Given this list of marker genes ITK (NCBI Gene Id 3702), RASSF2, IFI30, SELPLG, BLM, BPNT2, SLC18A2, KIF2C, FN1 (fibronectin 1), CYTIP, CCDC88A, LTB, RET, TNC, CALU, BCAT1, TRIP13, HHIPL2, GNLY, SLC16A3, SERPINA6, BIRC5, MMP12, CDC20, CHST11, CD6, IGHV3-33, COL5A1, IL18R1, CEP55, TRAC (T cell receptor alpha constant), TCL1A, MMP11, EVI2A, LMO3, LCK, HLA-DRB1, GZMA, ISG20 (NCBI Gene Id 3669), CCN4, AIF1, APOBEC3B, OIP5, GINS2, CNTNAP2, HLA-DRB6, GPR183, MMP1, ITGB2, CD79B, IGKV1OR2-108, CD52, LILRB4, PSTPIP1, LRRC15, IGHV3-21, TDO2, HSD17B1, GLIPR1, CST7, MMP19, CREB3L1, MMP3, CPM, CCL11, GPR171, AHI1, IGLV3-19, GPSM2, CD40, TYMS, IGHV1-69, NEK2, IGKV1D-8, NARS2, RRM2, MMP9, SOAT1, APOC1, LST1, CD27, ADCY7, TRAF3IP3, CCR7, CD38, CDKN3 (cyclin dependent kinase inhibitor 3), TPK1, NPL (N-acetylneuraminate pyruvate lyase), GZMB, SELL, GPR65, THEMIS2, CD79A, LAMP3, TBC1D31, IGLV4-60, CALCRL, GINS1, FCGR3A, EGFL6, FCMR, DOCK2, PLAC8, LILRB2, TRBC1, TK1, SULF1, SQLE, FANCI, IGHV3-20, DTL, CXCL9, PLAUR, CLEC7A (NCBI Gene Id 64581), TPX2, STAG3, LOXL1, TRDC, COL11A1, DSC2, ARHGAP15, SLA, IGHG1, SLC7A5, CCNA2, CD1E, CXCL10, GZMK, CYLD, CD53 (CD53 molecule), S100P, GBP1, PTPRC, CD74, KMO, GRB2, CD2, LRP8, ADGRE2, CKS2, PRR16, CD3D, TRGC1, VCAN, CENPF, ITGAX, NET1, BCL2A1, MNDA, CCL4, DLGAP5, FCGR2A, LAPTM5, NID2, CHIT1, HYAL1, IL18, INHBA, GAB2, CH25H, MAP4K1, FKBP11, CDH11, SAMSN1 (SAM domain, SH3 domain and nuclear localization signals 1), CTSC, CCR1, SOX11, PRKCB, ITGA4, LGALS9, NUSAP1, TRBC2 (NCBI Gene Id 28638), HLA-DQA1, CCNB2, COTL1, LAT2, CD48, IGHV3-7, MAFB, CD19, CPNE7, IGKV1D-13, ECM1, ADAMDEC1, TOP2A, STAT4, MCM4, LCP2, SPC25, CD86 (CD86 molecule), CD69, IGHV3-47, BUB1B, TNFAIP6, FCER1G, AIM2, CDK1, EPPK1, MMP13, ADAM12, FCGR3B, COL6A3, EVI2B, VCAM1, GDF15, CXCR4, AURKA, CENPA, PRC1, MS4A1, KDELR3, CEACAM6, IL2RG, CXCL13 (NCBI Gene Id 115545), PRUNE2, IRAG2, ASPM, ARHGAP25, BTK, CEACAM5 (NCBI Gene Id 1048), CCNE2, NDC80, TRAT1, SP140, CD163 (NCBI Gene Id 9332), UTS2, TFEC, RHOF, EPYC, RSAD2 (NCBI Gene Id 91543), CSF2RB, SLC7A7, CXCR3, MAD2L1, STK17B, SLAMF8, COL5A2, IGHV3-23, LPXN, FPR3, LY96, SRGN, NCAPG, RAD51AP1, LYZ, PBK, CCL18, RGS16, GREM1 (NCBI Gene Id 7947), IGHV4-61, CEMIP, CPPED1, HOPX, IGHM, PTTG1, PCLAF, FAP, LILRB1, BCL2L11, PLA2G7, KIF20A, DSCC1, PIGR, IRF8, LGALS2, CCL3, CTSS, DIO1, NCF2, MAN1A1, CCL8, PLEK (pleckstrin), BANK1, COL10A1, IGHV4-34, CENPU, ABCC4, MELK, FCGR1A, HS3ST3A1, KIF11, RGS4, IL32 (NCBI Gene Id 9235), HCLS1, FYB1, HLA-DMB, CXCL11, IGLV3-10, TRAF1, SERPINE1, KIF15, TNFSF4, here is a description of the gene set: from publication Poola I, DeWitty RL, Marshalleck JJ, Bhatnagar R, Abraham J, Leffall LD (PMID 15864312) Genes up-regulated in atypical ductal hyperplastic tissues from patients with (ADHC) breast cancer vs those without the cancer (ADH). Breast cancer is the second leading cause of cancer death for women in the United States. In 2005, about 215,000 cases of invasive breast cancer (IBC) and 50,000 cases of ductal carcinoma in situ will be diagnosed and 40,000 women will die of IBC in the US. Yet there is presently no molecular marker that can be used to detect a precancerous state or identify which premalignant lesions will develop into invasive breast cancer. Here we report the gene expression analysis of atypical ductal hyperplastic tissues from patients with and without a history of breast cancer. We identify MMP-1 as a candidate marker that may be useful for identification of breast lesions that can develop into cancer. species: Homo sapiens Human Gene Set: POOLA_INVASIVE_BREAST_CANCER_UP